Given this list of marker genes SLC7A4, SLC15A4, SLC38A5, TMEM44, SLC25A2, SLC3A1, SLC7A7, SLC7A1, SLC7A3, SLC22A2, SLC25A15, SLC47A1 (solute carrier family 47 member 1), SLC38A4, SLC66A1, SLC7A2, SLC38A3, SLC25A29, SLC38A9, SLC7A6, SLC7A9, SLC66A1LP, here is a description of the gene set: species: Homo sapiens Enables the transfer of basic amino acids from one side of a membrane to the other. Basic amino acids have side chains with a positive charge at pH 7.3. Human Gene Set: GOMF_BASIC_AMINO_ACID_TRANSMEMBRANE_TRANSPORTER_ACTIVITY